The following is a description of a gene set: Any process that stops, prevents or reduces the frequency, rate or extent of skeletal muscle cell differentiation. Mouse Gene Set: GOBP_NEGATIVE_REGULATION_OF_SKELETAL_MUSCLE_CELL_DIFFERENTIATION studied in species Mus musculus, and this is the list of marker genes: Ephb1, Mir669a-9 (microRNA 4669a-9), Mir669a-6, Six4, Mir669a-1, Mir669a-2, Mir669a-3, Myocd (myocardin), Mir669a-8, Akirin1, Mir669a-7, Mstn, S100b, Mir669a-5, Mir669a-10, Mir669a-4